Given this list of marker genes HOXD13, KCNJ8, SALL1, ABCC9, SATB2, EFNB1, FGFR1, GPC4, ROR2, NXN, EP300, SALL4, FGFR2, CTCF, CREBBP, DACT1, GATA4, GLI3, SUMF1, FLI1, BMP2, here is a description of the gene set: An increase in width in one or more phalanges of the big toe. studied in species Homo sapiens Broad hallux phalanx Human Gene Set: HP_BROAD_HALLUX_PHALANX